The following is a description of a gene set: from publication Ho MC, Lin JJ, Chen CN, Chen CC, Lee H, Yang CY, Ni YH, Chang KJ, Hsu HC, Hsieh FJ, Lee PH (PMID 17009164) species: Homo sapiens BACKGROUND: Recurrence after hepatocellular carcinoma (HCC) resection is the major obstacle to improved survival. The presence of vascular invasion (VI) in pathology specimens is a well-known unfavorable prognostic factor for HCC recurrence. Though some VI-related genes have been reported, their association with recurrence-free survival is not known. We hypothesized that a gene expression profile for VI can predict the recurrence of HCC after liver resection. METHODS: Eighteen patients receiving complete HCC resection were included as a training group. Genome-wide gene expression profile was obtained for each tumor using a microarray technique. Datasets were subjected to clustering analysis supervised by the presence or absence of VI to obtain 14 discriminative genes. We then applied those genes to execute pattern recognition using the k-Nearest Neighbor (KNN) classification method, and the best model for this VI gene signature to predict recurrence-free survival in the training group was obtained. The resulting model was then tested in an independent test group of 35 patients. RESULTS: A 14-gene profile was extracted which could accurately separate ten patients with VI and eight patients without VI in the training group. In the test group, significant difference in disease-free survival was found between patients predicted to have and not to have recurrence (P =.02823). In patients with stage_I disease, this model can also predict outcomes (P =.000205). CONCLUSIONS: Using the 14-gene expression profile extracted from microarrays based on the presence of VI can effectively predict recurrence after HCC resection. This approach might facilitate personalized medicine for HCC patients after surgical resection. Human Gene Set: HO_LIVER_CANCER_VASCULAR_INVASION Gene expression signature of vascular invasion of hepatocellular carcinoma (HCC)., and this is the list of marker genes: OGG1, SERPINB6, CSF3R, RPAP1, TAF4B, TRIM8, MAGEA9, AMPD3, UBE3C, CA2, RAB39A, ZNF687, RYR1